Given this list of marker genes EXOSC8, STAG2, HNRNPAB, DHX15, HNRNPA3P1, SUZ12, SERBP1, NUP153, HMGB1, TARDBP, EIF3A, XPO1, NUP50, SRP72 (signal recognition particle 72), SNW1, SUMO2, SNRPD1, RPA1, ANP32E, SRSF3, HAT1, CPSF6, TOPBP1, COPS3, CBX3, DKC1, HMGB2, SRSF2, CEP57, SMC4, SLC7A5P1, RAD21, MCM5, IFT25, TDG (NCBI Gene Id 93091), HNRNPM, PTGES3, ANP32B, SRSF1, SLBP, DEK, RBMX, PAPOLA, ZCCHC8, HNRNPU, SFPQ, PDS5A, VBP1, DUT, TRA2B, SRI, SSB, HNRNPR, VRK1, U2SURP, PTBP1, USP1, NCL, here is a description of the gene set: Neighborhood of DEK species: Homo sapiens Human Gene Set: GNF2_DEK Neighborhood of DEK DEK oncogene (DNA binding) in the GNF2 expression compendium